Given this list of marker genes Aldh8a1, Ahcyl, Kynu, Oaz1, Sardh, Kyat1, Mtrr, Ddo, Dao, Abat (4-aminobutyrate aminotransferase), Otc, Agxt2, Blmh, Kyat3, Aldh5a1, Cbs, Aldh6a1, Hoga1, Ahcy, here is a description of the gene set: studied in species Mus musculus Mouse Gene Set: GOBP_NON_PROTEINOGENIC_AMINO_ACID_CATABOLIC_PROCESS The chemical reactions and pathways resulting in the breakdown of non-proteinogenic amino acids.